Given this list of marker genes Lamtor4, Rragc (Ras-related GTP binding C), Tsc1, Lamtor5, Rraga, Lamtor1, Rheb, Prkag1, Prkag3, Lamtor2, here is a description of the gene set: species: Mus musculus This event has been computationally inferred from an event that has been demonstrated in another species.<p>The inference is based on the homology mapping from PANTHER. Briefly, reactions for which all involved PhysicalEntities (in input, output and catalyst) have a mapped orthologue/paralogue (for complexes at least 75% of components must have a mapping) are inferred to the other species. electronically inferred by orthology from the curated human pathway part of: MTOR signalling Reactome Pathway: Energy dependent regulation of mTOR by LKB1-AMPK